Given this list of marker genes mt-Co2, Cox7a2l, Ndufa4, Cox8b, Ndufa4l2, mt-Co3, Cox6c, Cox4i1, Cox6c2, Cox6a2, Cox5b, Cox6b1, Cox8a, AA467197, Cox7c, Cox6a1, Uqcrfs1, Cox7a1, Cox5a, mt-Co1, Cox4i2, Cox7a2, Cox6b2, Uqcrc2, Cox7b, Cox7b2, Cox8c, here is a description of the gene set: A part of the respiratory chain, containing the 13 polypeptide subunits of cytochrome c oxidase, including cytochrome a and cytochrome a3. Catalyzes the oxidation of reduced cytochrome c by dioxygen (O2). species: Mus musculus Mouse Gene Set: GOCC_RESPIRATORY_CHAIN_COMPLEX_IV